The following is a description of a gene set: Genes down-regulated in common hematopoietic progenitor cells isolated from bone marrow of patients with Diamond-Blackfan anemia (DBA) and mutated RPS19. studied in species Homo sapiens Human Gene Set: GAZDA_DIAMOND_BLACKFAN_ANEMIA_PROGENITOR_DN from publication Gazda HT, Kho AT, Sanoudou D, Zaucha JM, Kohane IS, Sieff CA, Beggs AH (PMID 16741228) Diamond-Blackfan anemia (DBA) is a broad developmental disease characterized by anemia, bone marrow (BM) erythroblastopenia, and an increased incidence of malignancy. Mutations in ribosomal protein gene S19 (RPS19) are found in approximately 25% of DBA patients; however, the role of RPS19 in the pathogenesis of DBA remains unknown. Using global gene expression analysis, we compared highly purified multipotential, erythroid, and myeloid BM progenitors from RPS19 mutated and control individuals. We found several ribosomal protein genes downregulated in all DBA progenitors. Apoptosis genes, such as TNFRSF10B and FAS, transcriptional control genes, including the erythropoietic transcription factor MYB (encoding c-myb), and translational genes were greatly dysregulated, mostly in diseased erythroid cells. Cancer-related genes, including RAS family oncogenes and tumor suppressor genes, were significantly dysregulated in all diseased progenitors. In addition, our results provide evidence that RPS19 mutations lead to codownregulation of multiple ribosomal protein genes, as well as downregulation of genes involved in translation in DBA cells. In conclusion, the altered expression of cancer-related genes suggests a molecular basis for malignancy in DBA. Downregulation of c-myb expression, which causes complete failure of fetal liver erythropoiesis in knockout mice, suggests a link between RPS19 mutations and reduced erythropoiesis in DBA., and this is the list of marker genes: HSDL2, IMPACT, PDZD8, PRKDC, PFDN4, RPL36, LYPLA1, APEH, PNPLA4, THOC7, ADK, CNOT8, VCY, CHPF2 (chondroitin polymerizing factor 2), IBTK, EXOSC10, CAD, LSM5, NAP1L1, LAMP2, SMARCA4, NUP54, HELLS, NOP56, MAPKAPK5-AS1, CASP6, ZNF84, CLGN, FABP5, FAM149B1, PRSS2, MAGT1, CCT6A, RB1, SKIC3, RAB4A (NCBI Gene Id 5867), NFYB, SEC61A1, FLT3, PXMP2, ZFX, PHGDH, PTPRD, TAX1BP1, NUCB2, NUDT2, NUP160, SPAST, GCSH (glycine cleavage system protein H), ELOC, BRCA2, CPSF6, ITPR2 (inositol 1,4,5-trisphosphate receptor type 2), ARL1, R3HDM4, PLAGL1, IGFBP7, SMC5, SPATA7, OXLD1, CDH2, TMSB15A, IFT74, ADCK2, UBA2, AGBL5